The following is a description of a gene set: T-cell acute lymphoblastic leukemia (T-ALL), unlike other ALL types, is only infrequently associated with chromosomal aberrations, but it was recently shown that most individuals with T-ALL carry activating mutations in the NOTCH1 gene. However, the signaling pathways and target genes responsible for Notch1-induced neoplastic transformation remain undefined. We report here that constitutively active Notch1 activates the NF-kappaB pathway transcriptionally and via the IkappaB kinase (IKK) complex, thereby causing increased expression of several well characterized target genes of NF-kappaB in bone marrow hematopoietic stem cells and progenitors. Our observations demonstrate that the NF-kappaB pathway is highly active in established human T-ALL and that inhibition of the pathway can efficiently restrict tumor growth both in vitro and in vivo. These findings identify NF-kappaB as one of the major mediators of Notch1-induced transformation and suggest that the NF-kappaB pathway is a potential target of future therapies of T-ALL. studied in species Mus musculus Genes down-regulated in bone marrow progenitors by constitutively active NOTCH1. from publication Vilimas T, Mascarenhas J, Palomero T, Mandal M, Buonamici S, Meng F, Thompson B, Spaulding C, Macaroun S, Alegre ML, Kee BL, Ferrando A, Miele L, Aifantis I (PMID 17173050) Human Gene Set: VILIMAS_NOTCH1_TARGETS_DN, and this is the list of marker genes: STOM, CSF1R, CSF2RA, LYZ, MATK, CMA1, CLEC10A, NCF2, ITGAM, CSF3R, LILRB1 (leukocyte immunoglobulin like receptor B1), MPO, ITGB2, ELANE, BTK, CTSG, CAMP (NCBI Gene Id 820), TREML1, PGLYRP1, TPSD1, NCF4, VPREB1, LRRC25, GFI1B, TREM2, CCL23, GFI1